Given this list of marker genes Tmie, Stk38, Yars2, Kif1b, Gimap6, here is a description of the gene set: Regulatory CD4+ T cells (Tr cells), the development of which is critically dependent on X-linked transcription factor Foxp3 (forkhead box P3), prevent self-destructive immune responses. Despite its important role, molecular and functional features conferred by Foxp3 to Tr precursor cells remain unknown. It has been suggested that Foxp3 expression is required for both survival of Tr precursors as well as their inability to produce interleukin (IL)-2 and independently proliferate after T-cell-receptor engagement, raising the possibility that such 'anergy' and Tr suppressive capacity are intimately linked. Here we show, by dissociating Foxp3-dependent features from those induced by the signals preceding and promoting its expression in mice, that the latter signals include several functional and transcriptional hallmarks of Tr cells. Although its function is required for Tr cell suppressor activity, Foxp3 to a large extent amplifies and fixes pre-established molecular features of Tr cells, including anergy and dependence on paracrine IL-2. Furthermore, Foxp3 solidifies Tr cell lineage stability through modification of cell surface and signalling molecules, resulting in adaptation to the signals required to induce and maintain Tr cells. This adaptation includes Foxp3-dependent repression of cyclic nucleotide phosphodiesterase 3B, affecting genes responsible for Tr cell homeostasis. Mouse Gene Set: GAVIN_IL2_RESPONSIVE_FOXP3_TARGETS_DN from publication Gavin MA, Rasmussen JP, Fontenot JD, Vasta V, Manganiello VC, Beavo JA, Rudensky AY (PMID 17220874) studied in species Mus musculus FOXP3 target genes down-regulated in T lymphocytes after stimulation with IL2.